The following is a description of a gene set: species: Homo sapiens from publication Blanco-Melo D, Nilsson-Payant BE, Liu WC, Uhl S, Hoagland D, Møller R, Jordan TX, Oishi K, Panis M, Sachs D, Wang TT, Schwartz RE, Lim JK, Albrecht RA, tenOever BR (PMID 32416070) Human Gene Set: BLANCO_MELO_COVID19_SARS_COV_2_INFECTION_CALU3_CELLS_DN Analysis of the transcriptional response to SARS-CoV-2 compared with other respiratory viruses, including MERS-CoV, SARS-CoV-1 (SARS), human parainfluenza virus 3 (HPIV3), respiratory syncytial virus (RSV), and IAV. Genes down-regulated in SARS-CoV-2 infection (Calu-3 cells, MOI: 2, 24hpi), and this is the list of marker genes: MXD3, TMT1A, TRMT9B, MIR31HG, PCOTH, SCGN, LRRC45, DDC (dopa decarboxylase), CLDN2, SOSTDC1, NPBWR1, PIERCE1, TM4SF4, ABCG5, SNRNP25, ANXA10, H2AX, EPN3, SMIM32 (small integral membrane protein 32), ANXA13, TEX15, SYT12, KCNK2, NEB